The following is a description of a gene set: The chemical reactions and pathways resulting in the breakdown of catechol-containing compounds. Catechol is a compound containing a pyrocatechol nucleus or substituent. Mouse Gene Set: GOBP_CATECHOL_CONTAINING_COMPOUND_CATABOLIC_PROCESS species: Mus musculus, and this is the list of marker genes: Moxd2, Slc6a3, Sult1a1, Comt, Moxd1, Pde1b, Tomt (NCBI Gene Id 791260), Dbh, Maoa